The following is a description of a gene set: Mouse Gene Set: GOBP_POSITIVE_REGULATION_OF_GAP_JUNCTION_ASSEMBLY species: Mus musculus Any process that activates or increases the frequency, rate or extent of gap junction assembly., and this is the list of marker genes: Cav1, Ace2 (angiotensin converting enzyme 2), Hopx, Irx3 (Iroquois related homeobox 3), Tbx5 (NCBI Gene Id 21388), Cntnap2, Agt